Given this list of marker genes Hbp1, Bbip1, Six3, Apc2, Zranb1, Axin2, Mdk, Tmem170b, Strn, Pin1rt1 (NCBI Gene Id 241593), Apcdd1, Fzd6, Gsc, Tmem9, Lzts2, Tle2, Prickle1, Sox30, Grk6, Fgfr2 (NCBI Gene Id 20946), Rnf213, Tlr2, Ndp, Foxd1, Arl6, Cdk14 (cyclin dependent kinase 14), Tnik, Nle1, Tert, Adnp, Lbx2, Hnf1b, Mamdc4, Mir32, Wnt2, Celsr2, Mir135a-2, Wnt5a, Tmem98, Lrrk1, Fermt2, Rspo1, Egfr, Rbms3, Ift20, Amer3, Fzd7, Gpc5 (glypican 5), Bicc1, Ccnyl1, Etv2, Klhl12, Mir154, Gli3, Ptpru, Fgf10, Jup, Paf1, Mark1, Bcl7b, Csnk2a2, Rac1, Csnk2a1, Ldb1, Gata3, Znrf3, Tpbg, Kank1, Rnf138, Zbed3, Ccdc88c, Lats1, Plpp3, Wnk1, Pten, Wnt8b, Daam1, Pin1, Tcf7l1, Hdac1, Mir15a, Lrp5, Nxn, Dvl1, Tpbgl, Tmem67, Hmga2, Pitx2, Hic1, Tle6 (transducin-like enhancer of split 6), Siah1a, Ednrb, Nphp4, Wnk2 (NCBI Gene Id 75607), Dact1 (NCBI Gene Id 66738), Bmp2, Pbxip1, Prdm15, Dvl2, Ctr9, Nppa, Gli1 (GLI-Kruppel family member GLI1), Vps4b, Mark2, Tiam1, Stk11, Pygo2, Gsdma3, Mir200a, Spef1, App, Sbno1, Drd2 (NCBI Gene Id 13489), Cer1, Wwtr1, Daam2 (dishevelled associated activator of morphogenesis 2), Tgfb1, Frzb, Tax1bp3, Ccdc134, Mllt3, Reck, Foxo3, Shisa2, Vangl2, Kremen2, Tmem237, Snai1 (NCBI Gene Id 98875), Barx1, Lect2, Map3k1, Dab2, Bambi, Vps35, Dkk3 (dickkopf WNT signaling pathway inhibitor 3), Usp8, Wnt16, Rnf43, Lrp6, Dab2ip, Zeb2, Ddit3, Tcf7l2, Cd44, Sox13, Psen1, Ccne1, Wnt9b, Gskip, Lmx1a (NCBI Gene Id 13485), Dkk1, Lrp4, Mdfic, Prkn, Mitf, Xiap, Ror2, Nog, Lgr6, 2210016L21Rik, Abl1, Cela1, Gsk3b, Trabd2b, Fuz (NCBI Gene Id 70300), Mapk14, Grem1, Wnt3a, Cdh1, Prkaa1, Ifrd1, Wnt2b, Fbxw11, Myc, Mad2l2, Scyl2, Hdac2, Mir27b, Sulf2, Csnk1a1, Wnt1, Notch1, Fzd4, Ccnd1, Med12 (mediator complex subunit 12), Dapk3, Ppm1n, Smarca4 (NCBI Gene Id 20586), Atp6v1c2, Epm2a, Fgf9, Cby1, Lypd6, Dcdc2a, Enpp1, Ubac2, Hnf1a, Thra, Fzd2, Dkk4, Zbtb33, Lef1, Shisa6, Mir20a, Cmah, Ptk7 (PTK7 protein tyrosine kinase 7), Senp2, Sostdc1, Tnks2, Cxxc4, Wnt11, Sost, Wnt4, Pygo1, Sox7, Wnt6, Siah2, Rspo2, Tgfb1i1, Kremen1, Rspo3 (R-spondin 3), Potefam3a, Mir182, Tle5, Foxo1, Fgfr3, Ilk, Rspo4, Ddx3x, Ppm1b, Ccny, Mir224, Ctnnd1, Nrarp, Frat2, Nphp3, Nkd2, Src, Cpe, Rab5a, Wnt7a (NCBI Gene Id 22421), Caprin2, Wnt3, Sox17 (SRY (sex determining region Y)-box 17), Depdc1b, Alpk2, Gpc4, Rac3, Tnn, Tmem88b, Ednra, Lgr5, Disc1, Ddb1, Dact3, Nkx2-5, Nfatc4, Potefam3b, Fzd5, Ctnnd2, Limd1, Edn1, Invs, Tle4, Fermt1, Siah1b, Asb15, Sema5a, Mesp1 (NCBI Gene Id 17292), Atp6ap2, Col6a1, Csnk1e, Trpm4, Isl1, Stk4, Brd7, Spin4, Klf15, Mks1, Rps12, Emd, Pkd1, Wwox, Btrc, Tle3, Wnt8a, Notum, Jrk, Fzd10, Ppp2r3a, Bmal1, Frmd8, Wls, Ifrd2, Wnt10b, Tbx18 (NCBI Gene Id 76365), Amotl1, Gnaq, Sox10, Sfrp4, Mir196a-2, Sfrp1, Wif1 (NCBI Gene Id 24117), Pias4, Tnfaip3, Ccar2 (cell cycle activator and apoptosis regulator 2), Smad7, Wnt7b, Gprc5b, Tle1, Cpz, Klf4, Dkk2, Tmem198, Rnf146, Nlk, Fzd3, Csnk1g1, Adgra2, Sfrp2, Fzd9, Ttc21b, Fbxw4, Itga3, Tcf7, Folr1, Fzd1, Stk3, Ptpro, Cdh2, Abl2, Mir221, Gid8, Frat1, Shh, Atp6v0c, Ext1, Ndrg2, Ccn4, Hesx1, Sdc1, Sdhaf2, Amfr, Amotl2, Ctdnep1, Mdfi, Wnt10a, Myoc, Smad3, Draxin, Mbd2, Smad4, Asb3, Mir135a-1, Bcl9, Vgll4, Lrrk2 (NCBI Gene Id 79409), Dkkl1, Ror1, Fzd8 (NCBI Gene Id 14370), Mir93, Ndel1, Cyld, Kpna1, Ankrd6, Ubr5 (ubiquitin protein ligase E3 component n-recognin 5), Egr1 (early growth response 1), Dvl3, Sox4, Tmem88, Mcc, Mdfic2, Ankrd66, Nkd1, Celsr3, Yap1, Mir195a, Shisa3, Fgf2, Lgr4, Otulin, Cdh3, Apoe, Spin1, Mir196a-1, Csnk1g2, Amer1, Rnf220, Rbpj, Col1a1, Ppm1a, Peg12, Cul3, Aida (NCBI Gene Id 72487), Tbl1xr1, Bcl9l, Ruvbl2, Usp47, Aspm, Csnk1d, Egf, Rack1, Tle7, Sall1 (NCBI Gene Id 58198), Tsku, Rtf1 (NCBI Gene Id 99410), Scel, Snai2, Usp34, Tbl1x, Eda, Jade1, Ctnnb1, Vax2, Sox9 (SRY (sex determining region Y)-box 9), Csnk2b, Gpc3, Nfkb1, Wnt9a, Sox2, Dixdc1, Rapgef1, Sulf1, G3bp1, Ctnnbip1, Fam53b, Csnk1g3, Mir222, Otud5, Calcoco1, Axin1, Dact2, Amer2, Lrp1, Mir200b, Cdc73, Krt6a, Lrrfip2, Prkaa2, Leo1, Ruvbl1, Tmem132a, Tmem198b, Crbn, Mir29b-1, Plekha4, Mir106b, Bbs4, Nherf1, Dlx3, Tnks, Vcp, Porcn, Cthrc1, Hm629797, Zfp703, Mir135b, Apc, Foxl1, Skic8, Wnt5b, Ube2b, Tmem131l, Rnf14, Pkd2, Grk5, Grb10, Macf1, Lats2, Hhex, Pfdn5, Sfrp5, Mesd, Ryk, D1Pas1, Tsc2, Snx3, Ift80, Cav1, Chd8, Tmem64, Dlx5, Gsk3a, Lmbr1l, here is a description of the gene set: The series of molecular signals initiated by binding of a Wnt protein to a frizzled family receptor on the surface of a target cell and ending with a change in cell state. studied in species Mus musculus Mouse Gene Set: GOBP_WNT_SIGNALING_PATHWAY